The following is a description of a gene set: studied in species Mus musculus A molecular function required for core promoter activity that mediates the assembly of the RNA polymerase holoenzyme at promoter DNA to form the pre-initiation complex (PIC). General transcription factors (GTFs) bind to and open promoter DNA, initiate RNA synthesis and stimulate the escape of the polymerase from the promoter. Not all subunits of the general transcription factor are necessarily present at all promoters to initiate transcription. GTFs act at each promoter, although the exact subunit composition at individual promoters may vary. Mouse Gene Set: GOMF_GENERAL_TRANSCRIPTION_INITIATION_FACTOR_ACTIVITY, and this is the list of marker genes: Taf6, Brf2, Taf5, Taf9b, Taf4b, Gtf2a1, Gtf2e2, Brf1, Tbp, Taf2, Foxa2, Prrx2, Gtf2e1, Taf12 (TATA-box binding protein associated factor 12), Taf11, Gtf2h3 (NCBI Gene Id 75968), Gtf3c1, Gtf3a, Rrn3, Taf7, Snapc5, Dr1, Taf6l, Drap1, Gtf2b (general transcription factor IIB), Tbpl2, Taf7l (NCBI Gene Id 74469), Gtf2f1, Taf10, Prrx1, Ccnh, Gtf3c4, Taf4, Ubtfl1, Snapc2, Gtf2a2, Gtf2h4, Ubtf, Taf9, Tbpl1, Taf1, Taf1c, Snapc4, Gtf2f2, Gtf3c5, Gtf2h2